Given this list of marker genes PRSS8, MAP2K6, ZNF37A, RAB9B, GABRA2, GPRIN3, SCN1A, PURG, CDH2, MIB2, KLF7, MAGIX, NUP62CL, CFAP68, MMP26, TBC1D13, FAM236A, RUFY3, IRF2BP1, ST6GALNAC4, RERE, RGS3, SOS2, DMBT1, FBLN5, RAP1GAP2, LINC02209, ATP1A2, H19, RLN2, CFAP43, ADGRG7, ZNF8, FAM151A, ERBB2, SNTB1, C10orf143, FBXO10, TCEAL3, LINC00917, MAGEB6, RAB37, CAMK2N1, ZNF575, PRR23E, YAE1, BOK, APBA2, LINC01346, IGSF9B, ZNF852, PDE9A, MCUB, NIFK-AS1, NLRP11, YBEY, PRKAG2-AS1, TMCO1-AS1, KIRREL2, ZNF251, CLEC11A, DTHD1, TTC32, FCGRT, PMS2P1, MIR124-1HG, ACCS, SLC13A4, TUB, CARD16, NDUFA10 (NADH:ubiquinone oxidoreductase subunit A10), TTC28-AS1, FKBP9, ADCY6, MID2, MROH2A, VIP, ZNF284, IL6ST-DT, TTC36, CD55, MYH14, TNFSF4, IQCN, NRBP2, PPIL6, CEP44, POU5F2 (POU domain class 5, transcription factor 2), SALL3, TNFRSF10B, RMST, FAM200B (family with sequence similarity 200 member B), PLIN5, RAI2, TACO1, NEIL1, TMEM60, CREB3L4, GARRE1, OR4D2, ENSG00000272447 (novel transcript), RSAD2, NT5M, FOXF1, FHOD3, MIR31HG, ZNF436-AS1, TIGD1, SIRT5, PIGC, CNTN3, SELENON, EID2B (NCBI Gene Id 126272), ZNF621, CTF1, B3GALT5-AS1, RNF32-DT, ACVR1B, IFI44L, MAML2, WFDC10A, ZDHHC15, CALHM2, ARSK, QSOX1, SERPINH1, PGLYRP4, ZBED5-AS1, CDH4, MED12L, NGFR, NYNRIN, MYO5B, PAX9, CLCNKB, MESP2, CYSLTR1, MORF4L2-AS1, MST1 (NCBI Gene Id 4485), PTPRU (protein tyrosine phosphatase receptor type U), KLK13, ANK3, LINC00526, GSTM4, P2RX2, TNNI3K, SORT1, WIPI2, SCARNA15, CYP19A1 (cytochrome P450 family 19 subfamily A member 1), MACROH2A2, UBE2Q2P13, LINC01133, TEX13B, S1PR3, ST7L, RHOU, TPSG1, DNMT3A, PLAC8, ZEB1-AS1, IDO1, LINC01569, MMP20, MPRIP, PSME3IP1, AMIGO2, PCBP1-AS1, VSTM2A, GRASLND, USF2, C17orf50, ELAVL2, TRPM4, LINC01356, WWOX, IER5L, IGF2BP2, PAX1, IFITM1, RPP25L, ZNRF3, EYA2, ADH7, WASF3, CPNE7, TSPAN18, PIGM (NCBI Gene Id 93183), SHROOM3, OSGEPL1, here is a description of the gene set: from publication Lund R, Aittokallio T, Nevalainen O, Lahesmaa R (PMID 14607935) Genes up-regulated in CD4 T cells activated by anti-CD3 and anti-CD28: TGFB1 and IL4 (2h) versus TGFB1 and IL-12 (2h). Human Gene Set: GSE2770_TGFB_AND_IL4_VS_TGFB_AND_IL12_TREATED_ACT_CD4_TCELL_2H_UP Th1 and Th2 cells arise from a common precursor cell in response to triggering through the TCR and cytokine receptors for IL-12 or IL-4. This leads to activation of complex signaling pathways, which are not known in detail. Disturbances in the balance between type 1 and type 2 responses can lead to certain immune-mediated diseases. Thus, it is important to understand how Th1 and Th2 cells are generated. To clarify the mechanisms as to how IL-12 and IL-4 induce Th1 and Th2 differentiation and how TGF-beta can inhibit this process, we have used oligonucleotide arrays to examine the early polarization of Th1 and Th2 cells in the presence and absence of TGF-beta after 0, 2, 6 and 48 hours of polarization. species: Homo sapiens